The following is a description of a gene set: Binds to and stops, prevents or reduces the activity of a cysteine-type endopeptidase involved in the apoptotic process. Human Gene Set: GOMF_CYSTEINE_TYPE_ENDOPEPTIDASE_INHIBITOR_ACTIVITY_INVOLVED_IN_APOPTOTIC_PROCESS species: Homo sapiens, and this is the list of marker genes: GAS6, NAIP, PRDX3, BIRC8, PRDX5, VIL1, BIRC3, BIRC7, BIRC5, SERPINB9, TNFSF14, TNFAIP8, XIAP, NOL3, CD27, BIRC2